Given this list of marker genes MMP8, MIR142, IL33, PLCG2, NUPR1, IL18, CCL3, CTSC, TTBK1, MIR128-1, STAP1, TAFA3, TNF, TREM2, IL1B (NCBI Gene Id 3553), IL6, MIR206, LRRK2, here is a description of the gene set: studied in species Homo sapiens Human Gene Set: GOBP_POSITIVE_REGULATION_OF_NEUROINFLAMMATORY_RESPONSE Any process that activates or increases the frequency, rate or extent of neuroinflammatory response.